The following is a description of a gene set: A process that results in the assembly, arrangement of constituent parts, or disassembly of a presynaptic active zone. species: Mus musculus Mouse Gene Set: GOBP_PRESYNAPTIC_ACTIVE_ZONE_ORGANIZATION, and this is the list of marker genes: Pcdh17, Bsn, Rab3a, Rims2, Pclo (piccolo (presynaptic cytomatrix protein)), Rims1, Erc2, Rimbp2, Ctbp2, Nlgn1, Erc1